The following is a description of a gene set: A nonspecific term referring to disease or damage of the kidneys. studied in species Homo sapiens Human Gene Set: HP_NEPHROPATHY Nephropathy, and this is the list of marker genes: MT-ND4, NUP107, NLRP3, CEP290, WDR73, COL4A5, KIAA0753, KCNJ11 (potassium inwardly rectifying channel subfamily J member 11), INPP5E, MT-TH, CPOX, VIPAS39, NEUROD1, SLC2A2, WFS1, TREX1, TTR, YRDC, GON7, TPRKB, PAX4, WAS, VPS33B, SEC61A1, DYNC2LI1, MMACHC, INS, ZNF423, WIPF1, IFT140, MYH9, NPHP1, PAFAH1B1, PRODH, MT-ND6 (mitochondrially encoded NADH:ubiquinone oxidoreductase core subunit 6), WDR4, WDR19, SCNN1A, APPL1, CEP120, MEFV, OSGEP, SCNN1B, DYNC2I1, TMEM237, CCND1, CC2D2A, SLC26A4, FGA, HIC1, PDX1, WT1, MT-TF, FAM20A, LAGE3, MT-ND1, CEL, NUP133, TP53RK, TMEM231, DYNC2I2, SAA1, PRDX1, ABCC8, MT-TQ, TMEM138, ADA2, MT-CO2, CLDN19, SLC5A2, MAFB, MT-CO1, PAX6, SMARCAL1, DYNC2H1, NOD2, HNF4A, FOXI1, BLK, TTC21B, MT-TS2, HNF1A, SCNN1G, KLF11, SCARB2, IFT172, MT-CO3, IFT80, GLA, YWHAE, KCNJ10 (potassium inwardly rectifying channel subfamily J member 10), CISD2, GCK, RPGRIP1L, COL4A6, TMEM67, TMEM216, MT-ND5, HPRT1, MT-TL1, MT-TW